The following is a description of a gene set: part of: Transport of Mature mRNAs Derived from Intronless Transcripts Reactome Pathway: Transport of the SLBP independent Mature mRNA studied in species Homo sapiens Transport of the SLBP independent Mature mRNA through the nuclear pore., and this is the list of marker genes: NUP37, NUP98, POM121, NUP155, NUP107, NCBP1, NUP42, NUP153, NUP43, EIF4E, RAE1, NUP58, NUP214, AAAS, NUP93, NDC1, NUP205, SEC13, NCBP2, NUP188 (nucleoporin 188), POM121C, TPR, NUP62, NUP85, NUP35, NUP88, RANBP2, ALYREF, NUP160, NUP133, SEH1L, NUP54, NUP210, NXF1, NUP50